Given this list of marker genes Grm1, Trpv6, Psd3, Oas1f, Ecel1, Epha2, Nfix, Zcchc24, Limk2, Prrt2, Bphl, Bcl2l13, Rflnb, Camkv, Camk1d, Mknk2, Plvap, Rtl8c, Tspan7, Paqr7, Vwc2l, Parvb, Rapgef1, Mark2, Usp5, Cited4, Slc9a5, Spsb1, Kif21b, Tfap2b, Hsp90b1, Cdk16, Rnf44, Rgma, Wdr33, Ubtf, Raver1, Marchf9, Tubb4a, Rab39, Atg9a, Gga1, Nacc2, Trib1, Zcchc17, Atn1, Canx, Kcna1, Cabp5, Sbno2, Gphb5, Adam19, Dchs1, Rab43, Samd4b (sterile alpha motif domain containing 4B), Ncan (neurocan), Pgam1, Stxbp1, Cyp4a10, Mtcp1, Eif4g1, Septin4, Usp9x, Camsap1, Ube2m, Cryl1, Tspan9, Dcbld1, Eif1ad, Tnrc6b, Mid1, Tulp3, Gskip, Gdf10, Carmil1, Dedd2, Tmem63b, Ttyh3, Pdzd7, Srgap1, Ahdc1, Nfic, Zfp516, Fzd7, Rgs2, Nr5a1, Sema3f, Smpd3, Hs3st2, Slc15a1, Nfasc, Map1a, Pacs1, Myo16, Disp2, Notch2, Slc29a4, Sptbn4, Tram1, Dtx3, Chmp6, Nptx1, Tspan33, Arnt2, Jade2, Fam20b, Kcnk3, Coro2b, Castor2, Zfp408, Hr, Plppr2, Rbm43, Ago2, Zfp710, Sec24c, Astl, Nr6a1, Iqsec2, here is a description of the gene set: from publication Chen Y, Wang X (PMID 31504780) studied in species Mus musculus Mouse Gene Set: MIR_7067_5P Genes predicted to be targets of miRBase v22 microRNA mmu_miR_7067_5p in miRDB v6.0 with MirTarget v4 prediction scores > 80 (high confidence targets).